The following is a description of a gene set: Catalysis of the reactions: ATP + a protein serine = ADP + protein serine phosphate; ATP + a protein threonine = ADP + protein threonine phosphate; and ATP + a protein tyrosine = ADP + protein tyrosine phosphate. species: Mus musculus Mouse Gene Set: GOMF_PROTEIN_SERINE_THREONINE_TYROSINE_KINASE_ACTIVITY, and this is the list of marker genes: Rps6kb1, Map2k5, Map2k2, Pak3, Akt1, Mapk8, Map2k7, Sbk2, Dyrk3, Rps6ka1, Prkaa2, Pbk, Map2k4, Sgk1, Rps6ka2, Prkcg, Dstyk, Prkaca, Dyrk1b, Pdk4, Tnk2, Acvr2b, Clk3, Mapk9, Clk2, Ttk, Dyrk4, Map2k1, Dyrk1a, Clk4, Map3k1, Map2k6, Braf, Map3k7, Tesk1, Map2k3 (NCBI Gene Id 26397), Clk1, Dyrk2, Tesk2